Given this list of marker genes TFDP2, ANAPC2, ANAPC1, CDKN1C, CDC26, CDK4, UBE2D1, SKP2, CDK6, UBE2E1, CCNE2, ANAPC16, ANAPC7, ANAPC4, ANAPC11, CDKN1B, CCND1, CCND3, E2F3, E2F2, RB1, CDC23, ATRX, FZR1, CCND2, CDKN1A, ANAPC15, CCNE1, CDC27, ANAPC10, E2F1, UBE2S, CDK2, TFDP1, CDC16, DAXX, UBE2C, ANAPC5, here is a description of the gene set: Diseases of mitotic cell cycle Human Gene Set: REACTOME_DISEASES_OF_MITOTIC_CELL_CYCLE species: Homo sapiens